The following is a description of a gene set: Genes having at least one occurence of the motif AAGTCCA in their 3' untranslated region. The motif represents putative target (that is, seed match) of human mature miRNAs hsa-miR-422b and hsa-miR-422a (v7.1 miRBase). Human Gene Set: AAGTCCA_MIR422B_MIR422A studied in species Homo sapiens, and this is the list of marker genes: BLTP3B, NSD1, MECOM, HECTD2 (HECT domain E3 ubiquitin protein ligase 2), TMEM245, YWHAQ, EN2, SSH2, MORF4L2, STXBP5, NEK4, DHX30, EDN1, JADE2, CREBRF (CREB3 regulatory factor), LRRFIP2, NSD2, AGO1, ZNF182 (zinc finger protein 182), BACE1, PRKAR2A, SPEG, DSCAM, NEXMIF, NTRK3, LUC7L3, PPP3CA, CSNK1G2, SRSF3, NT5E, GNAI2, RAP1B, IQSEC2, SYNE3, PHF21A, BZW1, FMOD, ARGLU1, RBBP5, FOXG1, KIF14, GADL1, FNDC3B, PAPOLB, C1orf21, NPAS4, APPL1, FRMD5, ALG3, SYN2, VCPIP1, PIK3CA, CALN1, ELP5, GSPT1, SOX6, ZIC4, PLAGL2, HAS3, STIM1, ZNF664, UPF3B, PTPRT (protein tyrosine phosphatase receptor type T), ACACA, SRR, NIBAN1, GOLT1A, CUX2, ASXL1, GNAT1, DLG2